Given this list of marker genes Sec31a, Tmem150c, Enoph1 (NCBI Gene Id 97253), Gpat3, Gm20548, Vamp9, Plac8, Gm35172, Hnrnpdl, Gm16227, 4930458D05Rik (NCBI Gene Id 75802), Tmem150cos, Cycs-ps2, 5430416N02Rik, 2310034O05Rik, Gm16228, Mrps18c, Coq2, Gm16226, 9430085M18Rik, Gm38413, Gm8091, Helq, 4930405H06Rik, Nkx6-1, Cops4, Hnrnpd, Rasgef1b, Abraxas1, Cds1, Gm42133, Gm19620, Hpse, Gm26286, Gm36793, here is a description of the gene set: Mouse Gene Set: chr5E4 species: Mus musculus